Given this list of marker genes Cited2, Jag1, Lrp2, Stra6, Hey2, Sec24b, here is a description of the gene set: Mouse Gene Set: GOBP_PULMONARY_ARTERY_MORPHOGENESIS The process in which the anatomical structures of the pulmonary artery are generated and organized. The pulmonary artery is the artery that carries blood from the heart to the lungs. studied in species Mus musculus